The following is a description of a gene set: Chromatin. Human Gene Set: MODULE_421 species: Homo sapiens, and this is the list of marker genes: H2AC8, H2BC11, SNHG12, COX11, H2BC21, TRMT2A, H2AC18, SCNN1B, CENPA, H1-2, H1-0, H2BC12, H2AC6, POLR1E (NCBI Gene Id 64425), LCN2, EXOSC10, RUSF1, ATM, CENPF, H2AX, CENPE, SEC14L1, ANXA1, TOX, TMEM41B, OGT, H2BC13, HMGB2